Given this list of marker genes HCK, C1orf162, CSF1R, MARCHF1, JARID2, FTH1, SGK1, PSAP, HSPA1B, IER5, LILRB3, ATP2B1-AS1 (ATP2B1 antisense RNA 1), PTPN6, RNASE6, IRAK3, FCN1, LILRB2, PLEK, FCER1G, IL1B (interleukin 1 beta), CLEC7A, CCR1, VCAN, ADA2, ATP2B1, S100A9, AIF1, TGFBI, DNAJB1, HSPB1 (NCBI Gene Id 3315), KLF2, MS4A7, HSP90AB1, CEBPB, HSPA1A, DNAJA1, PABPC4, HSPH1, PTPRE, BAG3, GADD45B, FCGR3A, FGD4, HCLS1 (NCBI Gene Id 3059), FGR, PTK2B, FCGR2A, TNFRSF1B, CCL3L3, MNDA, GPR183, NPC2, HLA-DPB1, RNF144B, FPR1, P2RX7, S100A11, SLC11A1, CXCL8, CPVL, TET2, HSP90AA1, VIM, HLA-DRA, CTSS, COTL1, APOBEC3A, MAFB, TNFAIP2, ZEB2, HLA-DMA, LILRB1, CYBB, CD37, RAB31, LYZ, CCDC88A (coiled-coil domain containing 88A), HK3, CST3, TLR2, FGL2, CD163, HLA-DQB1, IER3, CD83, C5AR1, ALOX5, LYN, HSPA6, TYROBP, HBEGF, HLA-DPA1, ITGAX, ATP6V1B2, HSPD1, BCL2A1, IGSF6, NCF1, ADGRE2 (adhesion G protein-coupled receptor E2), S100A8 (S100 calcium binding protein A8), AREG, POU2F2, LAPTM5, PLAUR, KLF4, PMAIP1, C3AR1, KCTD12, RILPL2, LST1, RGS2, MPEG1, SLC7A7, SAT1, NCF2, PHACTR1, MACROH2A1, SCIMP, EVI2B, SAMHD1, ANXA1 (NCBI Gene Id 301), here is a description of the gene set: species: Homo sapiens Human Gene Set: AIZARANI_LIVER_C18_NK_NKT_CELLS_5 from publication Aizarani N, Saviano A, Sagar, Mailly L, Durand S, Herman JS, Pessaux P, Baumert TF, Grün D (PMID 31292543)